The following is a description of a gene set: studied in species Mus musculus Cluster P3 of genes with similar expression profiles in peripheral T lymphocytes after FOXP3 loss of function (LOF). Human Gene Set: GAVIN_FOXP3_TARGETS_CLUSTER_P3 from publication Gavin MA, Rasmussen JP, Fontenot JD, Vasta V, Manganiello VC, Beavo JA, Rudensky AY (PMID 17220874) Regulatory CD4+ T cells (Tr cells), the development of which is critically dependent on X-linked transcription factor Foxp3 (forkhead box P3), prevent self-destructive immune responses. Despite its important role, molecular and functional features conferred by Foxp3 to Tr precursor cells remain unknown. It has been suggested that Foxp3 expression is required for both survival of Tr precursors as well as their inability to produce interleukin (IL)-2 and independently proliferate after T-cell-receptor engagement, raising the possibility that such 'anergy' and Tr suppressive capacity are intimately linked. Here we show, by dissociating Foxp3-dependent features from those induced by the signals preceding and promoting its expression in mice, that the latter signals include several functional and transcriptional hallmarks of Tr cells. Although its function is required for Tr cell suppressor activity, Foxp3 to a large extent amplifies and fixes pre-established molecular features of Tr cells, including anergy and dependence on paracrine IL-2. Furthermore, Foxp3 solidifies Tr cell lineage stability through modification of cell surface and signalling molecules, resulting in adaptation to the signals required to induce and maintain Tr cells. This adaptation includes Foxp3-dependent repression of cyclic nucleotide phosphodiesterase 3B, affecting genes responsible for Tr cell homeostasis., and this is the list of marker genes: SLC35D1, CAMK2N1, KHDC1L, BICD1, ENTPD1, TGIF1, EVI2A, CD74, SDR39U1, PNKD, SLC2A3, FAM81A, NAPRT, THEMIS, SAMSN1, GABARAPL1, GJB2, RNF216, RNF166, PGLYRP1, CLIP1, CBX7, SRSF2 (serine and arginine rich splicing factor 2), BCO2, PHLPP1, DGAT2, SFI1, CD80, DZIP1, PDE7A, FCMR, BIK, RHOBTB1, GNAQ, S100A4, MYO1E, CREM, CD200R1, ACP3, PATL2, IGHG1, JAK1, SORCS2, PPM1L, TGFBR3, EPHX1 (epoxide hydrolase 1), IL21, CASP3, CYP4F8, SLC22A5, FGL2, GPD2, SOX4, AKAP7, PRDX6, TDRP, PEAR1, LAMC1, IL10RA, ACOXL, FAM234A, CD244, IL18R1 (interleukin 18 receptor 1), GRB7, SEMA4A, ACTR3B, NEO1, ACTG2, UAP1, POU2AF1, PKP4, HDAC9, C1QTNF6, RALGDS, CELA1, CYBB, ATP6V0A1, PTPRJ, CAMK2B, PRDM1, ARHGEF12, EPCAM, LYL1, ITSN1, SLFN12, PLXDC1, CASS4, PTPRVP (NCBI Gene Id 359807), CCRL2, MBP, TCF7, OGA, RNF144A, USP18, S100A6, NCMAP, CXCR6, ITCH, KY, ALDOC, RABGAP1L, MATN2, FRMD5 (NCBI Gene Id 84978), SERINC3, LGMN (NCBI Gene Id 5641), ABCA2, ITGAE, ZNF608 (NCBI Gene Id 57507), MATK, MALAT1, ATP6V0D2, TMBIM1, F13A1, KAT7, CD47, RIN2, ARMCX4, CCR8, ITGB5, BAIAP3, SLC15A2, IKBIP, SYTL2, SPTBN1, MTM1, ERCC8, ITGB8, FHIP1A, GGT1 (NCBI Gene Id 91347), IGFBP4, EHD3, GPR160, ALOX15B (NCBI Gene Id 247), PTPN13, SPOCK2, ID2, PRKCH, DNAJB13, DGKD, CC2D2A, SCART1, GALM, ARL5A, IGFLR1, PSEN2, ST14, RAPGEF5, GPR34, ST8SIA1, IRF5, IL18, CDCP1 (CUB domain containing protein 1), PDE2A, POU2F2, KLRG1, TSPAN3, SDC4, USP48, SP4, PDE3B, DHX37, MYO1F